The following is a description of a gene set: Human Gene Set: HP_ABNORMAL_LARYNX_MORPHOLOGY Abnormal larynx morphology Any anomaly of the structure of the larynx. species: Homo sapiens, and this is the list of marker genes: HDAC4, FERMT1, HYLS1, LMNA (NCBI Gene Id 7816), LAMB3, SCARF2, KRAS, PHIP, EDN1, MYMX, LRP4, RILPL1, COMT, EP300, PPM1D, LAMC2, FRAS1, HLA-DPB1, FGFR2, RALGAPA1, KAT6B, DYNC2I1, SMAD2 (SMAD family member 2), ADAMTSL2, RAI1, CTLA4, DYNC2H1, XPNPEP2 (NCBI Gene Id 7512), SOX4, GMNN, SYT1, COL12A1, PSAP, PTPN22, RTL1, SEMA3E, H3-3B, MEG3, LONP1, ROBO1, APC (APC regulator of WNT signaling pathway), SERPING1, PLG, CENPE, FGFR3, TCTN3, HLA-DPA1, JMJD1C, SLC26A2, MAP3K7, MATR3, SOX9, PRMT7, ARSL, LRP12, EFL1, EXTL3, UBE3B, SNIP1, SF3B4, NFIX, PKDCC, IFT80, MGP, CACNA1C, KRT5, LAMA3, ATP6V1E1, KANSL1, KAT6A, SPTBN1, CREBBP, HS3ST6, RFX7, TONSL, FOXE1 (forkhead box E1), CAPN15, SETBP1, GP1BB, INTU, CHD7, C2CD3, PUF60, WDR35, DYNC2I2, BRF1, H3-3A, ADARB1, RPL10, ASAH1, FREM2, GLI3, PCNT, FLNA, TBX3, RREB1, DYNC2LI1, TBX1, UFD1, GRIP1, HOXD13, KIF22, PRRX1, KRT14, ASXL3, FBXW7, FLII, EIF4A3, WRN, DDRGK1, MYMK, CTSK, AFF4, ZIC3, DEAF1, FGF10, PRTN3, RAF1, MEIS2, ARVCF, POLR3A, POR, ORC6, NIN, KIF7, UFC1, HIRA, AHDC1 (NCBI Gene Id 27245), ZNF699, KCNMA1, HSPG2, GALC, HNRNPR, EPHB4, IDH1, NEK1, PTH1R, NRCAM, DTYMK, IQSEC2, MT-CYB, ZBTB7A (NCBI Gene Id 56976), FANCB, SIAH1, VPS13B, SMAD4, FLNB, GIPC1, CILK1, POLR1A, DLK1, SEC24C, SATB2 (NCBI Gene Id 80104), LTBP4, AMER1, LBR, NOTCH2NLC, MID1, LTBP3, HAAO